Given this list of marker genes Tirap, Il17a, Il17ra, Il17f, Trpv4, here is a description of the gene set: studied in species Mus musculus Any process that activates or increases the frequency, rate or extent of chemokine (C-X-C motif) ligand 1 production. Mouse Gene Set: GOBP_POSITIVE_REGULATION_OF_CHEMOKINE_C_X_C_MOTIF_LIGAND_1_PRODUCTION